Given this list of marker genes DNAJB14, STXBP6, MED26, ENY2, EXOC6B (NCBI Gene Id 23233), GNAI1, NUCKS1, PTPRJ, RAB6A, ADORA3, NSD1, MLC1, IDI2, PRTG, KPNA4, DRP2, DCUN1D4, VSTM2A, EP300, ANXA8, RIMKLB, KCNG3, MTMR2 (NCBI Gene Id 8898), SYT4, ANKRD50, KLHL24 (NCBI Gene Id 79965), ZZZ3, LARS1, RPP30, PPP1CB, BOLA2-SMG1P6, BPNT2, SNAPC1, CCDC157, ANXA4, BRWD3, GUCY1A2, MSL1, TRMT13, QSER1, ADAM23, HORMAD1, ERAP1, COL4A5, PCDH19 (protocadherin 19), NUFIP2, MTDH, PICALM, PRKAR1A, EDIL3, SP1, ARFIP1, SINHCAF, PCSK1, TAF12, RTBDN, C15orf61, STX6, MYSM1, RBL2, FMNL3, PDCD4, NKAPD1, IQGAP3, COL25A1, BRD2 (bromodomain containing 2), PRPF40A, FBXO42, TMEM127, SUMO2, NEURL1B, PHACTR2, RBM14, OSTM1, MARCHF4, GDAP2, POU3F4, ZNRF1, BRK1, ESRRG, ANXA8L1, HMBOX1, UBFD1, PTBP3, DACH1 (dachshund family transcription factor 1), PANK1, PTP4A2, WNK3, CXADR, ANKRD6, TNPO2, NTRK2, RABGEF1, TAFA2, CDC37L1, ADIPOR2, DNAL1, LRRN1, USP49, GNAQ, IFT70A, ATP5IF1, PABPN1, G6PC1, ANAPC10, VAPB, TBL1XR1, SGIP1, RC3H1, TNFRSF11B, CPEB2, NUP58, AMMECR1L, CHTF8, OSBPL1A, SOCS7, APOOL, COL6A3, GALNT13, STK35, PLA2G12A, SLC22A18AS (NCBI Gene Id 704), ABHD2 (NCBI Gene Id 654057), CCNJ, ZNF41, SRPX, UBE2G1, SLC12A8 (NCBI Gene Id 84561), ADNP, CUL4B, TMEM167B, RNF13, KIAA0319, HACE1, KMT2A, SDC1, OFD1, SPAG9, ATXN7L3B, RNF19A, ZMYM6, PROX1, SCD, POLI, PBX3, CNOT7, PAPPA, DYRK2 (dual specificity tyrosine phosphorylation regulated kinase 2), DCAF6, ZMAT3, SSTR1, TM9SF4, DNMT3B, CDKL3, TMX2, IL1RAP, RBFOX2, PGM2L1, BAZ2B, XG, VTA1, SLC44A5, SPATA8, HDDC2, SMAD2, STK17B (NCBI Gene Id 9262), MATCAP2 (microtubule associated tyrosine carboxypeptidase 2), ZNF695, MFAP3L, KCNG4, NAV1, NOXRED1, PHOSPHO1, NRSN1, LRRK2, ABCC9, SIRPB1, INO80D, GSK3B, THSD7A, PTPRQ, ATG4C, F2RL2, PAX4, SUMO1, TCTN3, HBD, CDIN1, PARP14, ZNF609, AUTS2, KIF1B, ANOS1, STK10, ATP6V1G1 (NCBI Gene Id 9550), PLA2R1, SH3TC2, EIF4E3, CADM2, HLF, SLC10A7, CHRDL1, ZNF680, NPR3, UBXN7, RAD54B, CACNA1E, PURA, PPP2R2B, EIF4E, TRNP1, DEDD, CAMK2D, AAK1, CADM1, PCNX1, AGER, CAPRIN1, BBS10, SLC39A12, ZNF562, FBXO32, BCL2L2-PABPN1, CES4A, RBM12, SMG1 (SMG1 nonsense mediated mRNA decay associated PI3K related kinase), GLUL, BTBD1, SRBD1, LRP6, CREB5, NOS1, NMNAT2, C4orf46, FSBP, RERG, PAPOLA, POU5F2 (NCBI Gene Id 134187), ELAVL2, A1CF, SPRY2, PPP1R12B, KLHL31, DOCK3, SRPX2, GLIS3, KLHL12, CD44, NAP1L1, MEAK7, DNALI1, RCC2, CHD6, TSN (NCBI Gene Id 7247), ZSWIM6 (NCBI Gene Id 57688), AHCYL1, GEMIN2, MED13L, SP6, KCNK13, CD300E, SLC39A14, ARHGAP6, MPPED2, ZNF703, here is a description of the gene set: from publication Chen Y, Wang X (PMID 31504780) Human Gene Set: MIR5584_5P Genes predicted to be targets of miRBase v22 microRNA hsa-miR-5584-5p in miRDB v6.0 with MirTarget v4 prediction scores > 80 (high confidence targets). species: Homo sapiens